Given this list of marker genes DCK, NME2, DUT, AK9 (NCBI Gene Id 401271), UCK1, NME6, CDA, PRPS1, DHODH, UCK2, NME1, AK5, UCKL1, CMPK2, UPP1, NME7, UPP2, NME2P1, CTPS2, NME4, CMPK1, UMPS, UPRT, NME9, NME5, DCTD, SHMT1, SLC4A7, DTYMK, CTPS1, TYMS, NME3, CAD, TBPL1, here is a description of the gene set: species: Homo sapiens The chemical reactions and pathways resulting in the formation of a pyrimidine nucleotide, a compound consisting of nucleoside (a pyrimidine base linked to a deoxyribose or ribose sugar) esterified with a phosphate group at either the 3' or 5'-hydroxyl group of the sugar. Human Gene Set: GOBP_PYRIMIDINE_NUCLEOTIDE_BIOSYNTHETIC_PROCESS